The following is a description of a gene set: Abnormal response to epinephrine as manifested by reduced or lacking aggregation of platelets upon addition of epinephrine. studied in species Homo sapiens Impaired epinephrine-induced platelet aggregation Human Gene Set: HP_IMPAIRED_EPINEPHRINE_INDUCED_PLATELET_AGGREGATION, and this is the list of marker genes: THPO, PLAU, MYH9, GFI1B, ITGB3, ITGA2B, SH2B3, RASGRP2, CALR